The following is a description of a gene set: The regulated release of a hormone into the circulatory system. Mouse Gene Set: GOBP_ENDOCRINE_HORMONE_SECRETION species: Mus musculus, and this is the list of marker genes: Vdr, Lep, Gdf9, Bmp6, Fzd4, Hcar2, Fgfr1, Retn, Crhbp (corticotropin releasing hormone binding protein), Ecrg4, Nkx3-1, Cyp19a1, Pparg, Cry2, Crhr1, Ucn2, Aqp1, Crhr2, Trpv6, Gata3, Tspo, Runx1, Pomc, Cga, Smad4, Dab2, Gja1, Rab11fip5, Ghrl, Cyp2j5, Inha, Crh, Agt, Mfn2, Ptpn11, Kcnq1, Tmf1 (NCBI Gene Id 414107), Apln, Npvf, Spp1, Lif, Gnas, Ucn, Acvr2a, Tac1, Pex5l, Tbx3, Tacr2, Foxl2, Inhba, Kiss1, Foxd1, Galr1 (galanin receptor 1), Rab8b, Nrg1, Rab11fip3, Fgfr4, Oprm1, Cyp27b1, Kdm5b, Il1b, Agtr2, Cry1, C1qtnf3, Agtr1a, Wnk4, Inhbb, C1qtnf1, Niban2, Rab11fip1, Oprk1, Gal, Ren1, Kcnk9 (NCBI Gene Id 402733), Selenom